Given this list of marker genes GATA1, GFI1B, RUNX1, IKZF5, NBEAL2, here is a description of the gene set: Human Gene Set: HP_ABNORMAL_ALPHA_GRANULES species: Homo sapiens Abnormal alpha granules Defective structure, size or content of alpha granules, platelet organelles that contain several growth factors destined for release during platelet activation at sites of vessel wall injury.